The following is a description of a gene set: Human Gene Set: GSE34156_TLR1_TLR2_LIGAND_VS_NOD2_AND_TLR1_TLR2_LIGAND_6H_TREATED_MONOCYTE_DN species: Homo sapiens human blood monocytes were isolated, activated and harvested at several timepoints In this study, we identified genes that were differentially expressed in human monocytes activated with eiter NOD2L and/or TLR2/1L. Genes down-regulated in monocytes (6h): M. tuberculosis 19 kDa lipopeptide versus M. tuberculosis 19 kDa lipopeptide and muramyl dipeptide. from publication Schenk M, Krutzik SR, Sieling PA, Lee DJ, Teles RM, Ochoa MT, Komisopoulou E, Sarno EN, Rea TH, Graeber TG, Kim S, Cheng G, Modlin RL (PMID 22447076), and this is the list of marker genes: DCHS1, HTR1A, TNFRSF14, TPH1, PARD6G, LEISA1, LINC02981 (NCBI Gene Id 442519), NAP1L3, TBC1D9B, LRRC14, PNMT, PTPA, CPE, PLLP, DPP10-AS1, ENSG00000275427, GAS6, OTUD7A (NCBI Gene Id 161725), MYO15B (myosin XVB), RYR2, PRAME, TOP1MT, MAP1S (microtubule associated protein 1S), ACAP3, SPACA6, TTYH2, TLL2, FGFR3, FBF1, REEP4, NMRK2, ILVBL, THSD4, TSEN34, EPHA10, AKR7A2, SCUBE1, PLEKHM2, SDSL, KIF2C, TRIM17, TNNC2, DRC12, C15orf61, MAK, LINC00957, SHD, MICAL3, IGLL1, AGPAT1, GAK, PDLIM1, HSPA4L, METTL26, PGAP1, TGM2, SMG1P2, PSG7 (pregnancy specific beta-1-glycoprotein 7), NLRP7, THAP7, LINC00705, HRCT1, PM20D2, RPL37, DCAF10, LINC01343, DPP10, LINC02076, PRLH, KRT9, OSBPL5, LINC00308, IL19, PCARE, CYP2D6, KRT85, USP2, MC1R, DNAH6, ZNF662, SMO, WFDC1, NOTUM, NEMP2 (NCBI Gene Id 100131211), CNTNAP1, NTN5, TPO, GLE1, TBXA2R, CYP4F29P, DNAH3, CRTC3 (CREB regulated transcription coactivator 3), C20orf181, TSSK6, MLF1, ALOXE3, COPS4, CA14, SELENOO, EPHX3, GUCY1A1, ADAM15, ATRN, TMC2, DECR2, SSTR3, IGHA1, CYP21A2, KIF1B, PPP2R3B, KCNMB2, GAL3ST3, BRSK2, ZNF584, VWCE, CD300LD-AS1, SLC1A6, CRB3, SEMA5B, RHBDL1, KDM8, ALX3, CLEC16A, NCAPD3, NISCH, RELL2, MGAT5B, YIPF1, RAI14, NICN1 (NCBI Gene Id 84276), LAMP5, MIA, MT2A, PSORS1C1, AKR1B10, ENSG00000229727, VTCN1, LRP3, MIR503HG, ITGA11, OCM2, ETV7, ITGA9, RNPEP, ADRA1B, TXNDC2, IKBKE, CASC16, SCN3B, ADAT3, LINC01089, CXCL12, ADGRE3, GABRE, POPDC2, SLC30A9, DEFB1, HEATR6, IFI27, SCN1B, ADAM20, MAB21L4, HTR1B, SLC14A2, TSSK3, CDH5, LINC00960, FAM200C, LINC01973, WNT9A, B4GALT2, ALDH7A1, PBXIP1, LINC01342, FAM181A, TLDC2, ZPBP, MTUS2, PLEK2, HEXIM2 (HEXIM P-TEFb complex subunit 2), PPIC, TREH, SLC28A3, SLC9A3-AS1, F2RL2